The following is a description of a gene set: Reactome Pathway: Evasion of Oncogene Induced Senescence Due to Defective p16INK4A binding to CDK4 studied in species Homo sapiens Missense mutations and small indels in the CDKN2A gene, which result in amino acid changes in p16INK4A that impair its ability to bind to CDK4, interfere with p16INK4A-mediated induction of cellular senescence in response to oncogenic signaling.<br>Loss-of-function mutations in p16INK4A can also contribute to cancer by interfering with p16INK4A-mediated inhibition of NFKB signaling. part of: Evasion of Oncogene Induced Senescence Due to p16INK4A Defects, and this is the list of marker genes: CDKN2A, CDK4 (NCBI Gene Id 92978)